The following is a description of a gene set: studied in species Homo sapiens The covalent addition of a nitric oxide group to an amino acid within a protein. Human Gene Set: GOBP_PROTEIN_NITROSYLATION, and this is the list of marker genes: S100A8, TXN, NOS2, S100A9, GAPDH